Given this list of marker genes ADGRB2, ADGRB1, CSPG5, ADGRG1, HES6, NES, CCND2, GRIA2, VANGL2, METRN, OLIG1, HES5, OLIG2, ADGRL3, DLL3, MAP2, PTPRZ1, PCSK1N, CRMP1, CELSR2, SHC3, MAGED4B, here is a description of the gene set: Genes up-regulated in glioblastoma cell lines displaying spherical growth (cluster-1) compared to those displaying semiadherent or adherent growth phenotype (cluster-2). Human Gene Set: GUENTHER_GROWTH_SPHERICAL_VS_ADHERENT_UP studied in species Homo sapiens from publication Günther HS, Schmidt NO, Phillips HS, Kemming D, Kharbanda S, Soriano R, Modrusan Z, Meissner H, Westphal M, Lamszus K (PMID 18037961) Tumor cells with stem cell-like properties can be cultured from human glioblastomas by using conditions that select for the expansion of neural stem cells. We generated cell lines from glioblastoma specimens with the goal to obtain model systems for glioma stem cell biology. Unsupervised analysis of the expression profiles of nine cell lines established under neural stem cell conditions yielded two distinct clusters. Four cell lines were characterized by the expression of neurodevelopmental genes. They showed a multipotent differentiation profile along neuronal, astroglial and oligodendroglial lineages, grew spherically in vitro, expressed CD133 and formed highly invasive tumors in vivo. The other five cell lines shared expression signatures enriched for extracellular matrix-related genes, had a more restricted differentiation capacity, contained no or fewer CD133+ cells, grew semiadherent or adherent in vitro and displayed reduced tumorigenicity and invasion in vivo. Our findings show that stable, multipotent glioblastoma cell lines with a full stem-like phenotype express neurodevelopmental genes as a distinctive feature, which may offer therapeutic targeting opportunities. The generation of another distinct cluster of cell lines showing similarly homogeneous profiling but restricted stem cell properties suggests that different phenotypes exist, each of which may lead to the typical appearance of glioblastoma.